Given this list of marker genes DUSP16, IL6R, IL6, DUSP6, MAPK3, TYK2, DUSP9, DUSP8, IL6ST (interleukin 6 cytokine family signal transducer), CDK1, DUSP4, JAK2, DUSP1, DUSP10, JAK1, PTPN11, MAP2K2, MAPK1, DUSP5, PEA15, MAP2K1, DUSP7, DUSP2, here is a description of the gene set: Human Gene Set: REACTOME_RAF_INDEPENDENT_MAPK1_3_ACTIVATION species: Homo sapiens RAF-independent MAPK1/3 activation